The following is a description of a gene set: Immune cell-specific expression is one indication of the importance of a gene's role in the immune response. In order to identify such patterns, we set out to broadly profile gene expression in a variety of immune cells. from publication Abbas AR, Baldwin D, Ma Y, Ouyang W, Gurney A, Martin F, Fong S, van Lookeren Campagne M, Godowski P, Williams PM, Chan AC, Clark HF (PMID 15789058) studied in species Homo sapiens Human Gene Set: GSE22886_CD8_VS_CD4_NAIVE_TCELL_DN Genes down-regulated in comparison of naive CD8 T cells versus naive CD4 T cells., and this is the list of marker genes: CSGALNACT1, RHO, UPP1, C10orf95, SLC6A8, TBX1, MRTFA, CASP10, LMBR1L, SAMHD1, TACR1, FXYD3, SPG7, CST4, ZNF287, CLASRP, FCGR2C, ATP1A1, LGI2, EPHB6, TPCN1, CARD9, MFGE8, MAP4K2, MAPT, CACNA1I (calcium voltage-gated channel subunit alpha1 I), BCAP29 (NCBI Gene Id 55973), ATXN7L3B, PTK2, CDC42EP4, POMT2, TAF15, PTGER1, CADM4, SCNN1A, ZNF467 (zinc finger protein 467), TENT4A, AKT2, CD22, GABBR1, ATXN7, ZFC3H1, VAT1, DSCC1, N4BP2L2-IT2, CHD7, ALDOAP2, HLA-DOA, CADM3, IL1RL1, RAB5C, DKFZP434A062, RASGRP2, NEU2, TRIM25, MTSS2, ATG9A (autophagy related 9A), SUGCT, MAGEH1, GP1BA (glycoprotein Ib platelet subunit alpha), C1orf54, ARHGEF1, DLX6, MXI1, CD5, LMTK2, GFRA3, SLC22A1, CYTH1, SCAF4, GAS2L1, HKDC1, SMARCB1, FAM13A, HECA, LINC00342 (NCBI Gene Id 150759), GYS2, CSAD, SPINT1, CREBBP, ALS2CL, RNF126P1, TRIB2, TNS2, HLA-DQB2, MISP, ZBTB22, TIAM1, TAF9B, S100A14, SCAND2P, SORBS3, GPA33, CLDN9, ECE1, PRB1, TMEM212, E2F2, RARA, FUT9, CAPRIN2, IL4R, CD33, CCL21, HTR5A, KCNK7 (NCBI Gene Id 10089), ZNF362, ARMC6, WNT7A, NCOA2, DENND5A (DENN domain containing 5A), OSER1, MYO15B, ZNF205, RERE, NPHS1, GARRE1, DAB1, PALM (NCBI Gene Id 5064), OXTR, GFAP, DENND2A, PGAP1 (NCBI Gene Id 80055), F5, GJB3 (gap junction protein beta 3), CCZ1, CYLD, MPP1, NLRP1 (NLR family pyrin domain containing 1), MAP3K1, LGALS9, GORASP1, LIPE, APOA2, SORBS1, ZNF587, CD4, ILF3, SH2B1, CACNG5, GSTT4, SIGLEC6, ZBTB20, UNC119, ENTPD4, PIM2 (NCBI Gene Id 11040), CDKN2C, VPREB3, APP, ATP11A, NECTIN2, PRMT8, PELI1, RAB40C, KAZALD1, PAPSS2, CLUHP3, ICOS, CRYM, ANK1, SH2B2 (NCBI Gene Id 10603), KLF3, ONECUT1, CEMP1, PODNL1, AP3M2, TLE2, CTSL, OAZ3, FAM110D, P2RX4, NFKBIL1, REEP2, GNG11, SEMA3B, SALL2, SECTM1, TNP1, WWP1, FOLR2, FUZ, RHBG, C1QA, PILRA, PLAU, FASTKD5, PLCH1, MAL, ZFHX2, NKTR, ARID5A, INTS1, DNASE1L3, FOXB1, ENPP3, LZTS3